Given this list of marker genes AARS2, MTMR7, HGS, FAN1, ZNF512, C5orf24, NFYA, RBM8A, DYNC1I2, CAND1, UPF3A, RAN, KIAA1191, MEPCE (NCBI Gene Id 56257), ZNF133, OSBPL2, OTUD6B, BABAM1, PRXL2A, ZBED1, ZNF384, EDNRA, UBE2E3, KDM3B, MSL1, VPS26B, MARK4, UBR7, CS, ZNF529, MFAP3, UFSP2, FOXO3, NAB1, NUP133, MED17, RNF41, IPO9, BRPF3, PRDM4 (PR/SET domain 4), FNTB, SLC35E2A, RPL7L1, HAPSTR1, ISCA1, FAM168B, MYO9A, THTPA (NCBI Gene Id 79178), TMEM245, LIG3, TNPO2, ANKRD10, PHF10, BCL2L1, APBB3, IQCK, VPS52, COMMD9, SNX15, USP33, KMT2A, NAA25, PRRC2B, TRAPPC14, TEX261, TMEM106B, DHX36 (DEAH-box helicase 36), ARFGAP1, RABGEF1, CHD9, TAF9B, IPO5, PHC1, RBM6, BTRC, SIN3A, RMDN3, KIDINS220, GSPT1, HECTD3, CENPO, BAZ2A, OCIAD1, AGAP4, TBC1D10B, ERAL1, HECTD1, TRIM33, AP2A1, MAEA, CHTOP, RALGAPA1, AAAS, GORASP1, TBCK, TARDBP, SS18L1, SETD1A, ATG4B, WSB2 (NCBI Gene Id 55884), CFAP298, PHF2, TTC17, LUC7L2, GPBP1, METTL17, BOD1L1, CSRNP2, ING4, DCTN4, TMEM120A, COPZ1, SOCS4, POGZ, KLHL12, DHX40, ASB3, JKAMP, ATG2B, ANKRA2, KHDC4, ZNF286A, RABL2B, BAHD1, EPM2AIP1, PPM1B, WNK1, COG5, BRD9, MFSD8, CLEC16A, ZFAND5, ABHD16A, MRPS5, SLC35B2, CIZ1, SELENOI, SAP130, PJA2, EHBP1, APOC4, LINC01278, CNPPD1, ZNF84, NAA30, KLHL11, PRKRA, NGRN, PREP, ATP2C1, CRNKL1, EVI5L, VEZT, MTMR4, NF2 (NCBI Gene Id 654093), TSEN34, XYLT2, VPS53, XPO6, MICALL1, NAPG, SH2B1, B4GALT2, ZNF644, WDR6, CPLANE1, PPIG, EPC2, C2CD5, here is a description of the gene set: Human Gene Set: GCM_GSPT1 Neighborhood of GSPT1 G1 to S phase transition 1 in the GCM expression compendium Neighborhood of GSPT1 species: Homo sapiens